The following is a description of a gene set: Any process that modulates the establishment or extent of a membrane potential in the polarizing direction towards the resting potential in an atrial cardiomyocyte. studied in species Homo sapiens Human Gene Set: GOBP_REGULATION_OF_ATRIAL_CARDIAC_MUSCLE_CELL_MEMBRANE_REPOLARIZATION, and this is the list of marker genes: NPPA, KCNQ1, KCNE5, MIR328, FLNA, KCNA5, SCN5A, CACNA1D (NCBI Gene Id 776)